Given this list of marker genes FTMT, BOLL, TSSK6, ZPBP2, ADAM30, SOX30, AURKC, REC8, MORC1, BRDT, LPIN1, DKKL1, GTF2A1L, TRPM4, SYCP1, ACRBP (acrosin binding protein), INSL6, CMTM2, TULP2, SPO11 (NCBI Gene Id 23626), MOV10L1, CRISP2, ODF2, CATSPER2, GAPDHS, TCP11, PRSS50 (serine protease 50), HSPB9, PLAAT5, STK31, CABYR, RPL10L, SYCP2 (NCBI Gene Id 10388), SPACA1, TPTE, PAPOLB, SHCBP1L, DAZL (NCBI Gene Id 1618), SPATA22, POTEB, ZPBP, POTEG, RBMXL2, here is a description of the gene set: from publication Weber M, Hellmann I, Stadler MB, Ramos L, Pääbo S, Rebhan M, Schübeler D (PMID 17334365) To gain insight into the function of DNA methylation at cis-regulatory regions and its impact on gene expression, we measured methylation, RNA polymerase occupancy and histone modifications at 16,000 promoters in primary human somatic and germline cells. We find CpG-poor promoters hypermethylated in somatic cells, which does not preclude their activity. This methylation is present in male gametes and results in evolutionary loss of CpG dinucleotides, as measured by divergence between humans and primates. In contrast, strong CpG island promoters are mostly unmethylated, even when inactive. Weak CpG island promoters are distinct, as they are preferential targets for de novo methylation in somatic cells. Notably, most germline-specific genes are methylated in somatic cells, suggesting additional functional selection. These results show that promoter sequence and gene function are major predictors of promoter methylation states. Moreover, we observe that inactive unmethylated CpG island promoters show elevated levels of dimethylation of Lys4 of histone H3, suggesting that this chromatin mark may protect DNA from methylation. studied in species Homo sapiens Human Gene Set: WEBER_METHYLATED_HCP_IN_FIBROBLAST_DN Unmethylated germline-specific genes with high-CpG-density promoters (HCP) in primary fibroblasts.